Given this list of marker genes GMPS, IMPDH2, ATIC, ADA, PFAS, PAICS, GART (phosphoribosylglycinamide formyltransferase, phosphoribosylglycinamide synthetase, phosphoribosylaminoimidazole synthetase), AMPD1, HPRT1, IMPDH1, ADSL, PPAT, ADK, APRT, here is a description of the gene set: studied in species Homo sapiens The chemical reactions and pathways resulting in the formation of GMP, guanosine monophosphate. Human Gene Set: GOBP_GMP_BIOSYNTHETIC_PROCESS